Given this list of marker genes MUC2, ADAMTS18, GALNT3, MUC5AC, ADAMTS12, THSD7A, MUC20, SEMA5A, SPON2, ADAMTSL5, MUC7, SSPOP, SBSPON, GALNT12, THSD1, MUC1, ADAMTSL1, ADAMTSL2, C1GALT1, ADAMTS14, MUC12, ADAMTS6, MUC21, MUC4, B3GLCT, POMT1 (NCBI Gene Id 10585), ADAMTS2, SPON1, ADAMTS9, THSD7B, THBS2, NOTCH1, MUC16, MUC3A, C1GALT1C1, ADAMTSL4, ADAMTSL3, MUC17, POMT2, ADAMTS19, SEMA5B, NOTCH2, POMGNT1, MUC15, ADAMTS15, THBS1, ADAMTS20 (NCBI Gene Id 80070), ADAMTS5, ADAMTS13, NOTCH3, MUC19, ADAMTS7, B4GAT1, MUC6, NOTCH4, ADAMTS4, ADAMTS1, MUC5B, ADAMTS17, THSD4, LFNG, ADAMTS8, MUC3B, ADAMTS3, DAG1, LARGE1, ADAMTS10, MUCL1, ADAMTS16, CFP, MUC13 (NCBI Gene Id 65118), here is a description of the gene set: part of: Diseases of glycosylation Glycosylation is the most abundant modification of proteins, variations of which occur in all living cells. Glycosylation can be further categorized into N-linked (where the oligosaccharide is conjugated to Asparagine residues) and O-linked glycosylation (where the oligosaccharide is conjugated to Serine, Threonine and possibly Tyrosine residues). Within the family of O-linked glycosylation, the oligosaccharides attached can be further categorized according to their reducing end residue: GalNAc (often described as mucin-type, due to the abundance of this type of glycosylation on mucins), Mannose and Fucose. This section reviews currently known congenital disorders of glycosylation associated with defects of protein O-glycosylation. species: Homo sapiens Reactome Pathway: Diseases associated with O-glycosylation of proteins